The following is a description of a gene set: The aim of this study was to identify genes regulated by IL-12, IL-18 and IFN-alpha during early differentiation of human Th1 cells Genes up-regulated in the activated CD4 T cells (48h): IL-12 and IL18 versus interferon alpha. from publication Filén S, Ylikoski E, Tripathi S, West A, Björkman M, Nyström J, Ahlfors H, Coffey E, Rao KV, Rasool O, Lahesmaa R (PMID 20304822) studied in species Homo sapiens Human Gene Set: GSE20198_IL12_IL18_VS_IFNA_TREATED_ACT_CD4_TCELL_UP, and this is the list of marker genes: TRIM35, NUDT18, PLEKHA5, PHB2, TCOF1, BRCA2, FADS1, PSMD14, MGMT, GUF1, FLI1, CLHC1, IL4I1, PRKCD, IFT56, RNF38, ZFR2, TFB1M, AIM2, MRS2, OSBPL7, SEL1L (NCBI Gene Id 6400), ALDOC, SMIM30, ITPRIPL2, BCL2L2, ZBTB9, STX4, INPP5B, NFIX, CIC, FLYWCH1, SLAMF6, TIMM8B, ZXDC, FBXO45, IPO11, METTL26, PAFAH2, IFT46, GSK3A, SCLY, PREB, CNPY4, MTHFD1L, PAPOLG, STMP1, TIFA, PSPH, MEDAG, DNAJC19, RPL3, NTHL1, ATP6V0A1, MRPL47 (mitochondrial ribosomal protein L47), XPO6, PRR14, PRKCSH, COX16, YWHAH, DYNLT2B, ZDHHC4, STK26, SMAD1, TPRA1, PITHD1, RCBTB1, ARMC2, ECI1, SESN3, AGRP, SMCO4, EIF4ENIF1, FAM161A, RPS8, HMG20A, CARD6, PIP4P2, BAX, BIN1, HELB, ZC4H2, AP1B1 (adaptor related protein complex 1 subunit beta 1), ZSWIM7, TMEM198, SLC39A3, ZMAT2, UNC50, ZNF692, NDRG3, MPEG1, C1orf174, KCTD11, ZC3H12D, PDE6D, TRAM2, ARFIP1, RAMP1, NUDT13, DNLZ, FBXO25, SPICE1, C1orf74, OPA1, IFT74, CCDC6, TBC1D13, RPUSD3, CHAF1B, TACC1, LGALS1, ASB4, FRA10AC1, ARHGAP22, DOCK6, NUDT12, NR1H2, POLR2I, VPS39, CSAD, ZMYND11, GLRX, SPPL2A, FGD5, GUSB, VAMP4, KLF7, PLBD2, TMA7, GANAB, ENDOU, DDX28, DNAJC10, SAA4, SLC52A3 (solute carrier family 52 member 3), PTPRCAP, AAMP, RAP2B, FKTN (NCBI Gene Id 2218), PPIH, CELA1 (chymotrypsin like elastase 1), GABRD, PHTF1, SFXN2, THAP11, UCHL1 (ubiquitin C-terminal hydrolase L1), SLC25A28, SPI1, SCAF1, EXOSC5, SERF2, UPF3A, KCNAB2, TTI1 (NCBI Gene Id 9675), DMAC2L, IDH3B, GATB, KIF3C, OTUD5, PARVG, THY1 (Thy-1 cell surface antigen), POLD2, ZNF606, CPSF1, DUS1L, C9orf85, RASSF2, IP6K1, CTH, GIT2, CCNDBP1, PCK2, GPR89B, NHERF2 (NCBI Gene Id 9351), TRIM68, SLC6A4, UXS1, APOBEC2, CA9, ARSK (arylsulfatase family member K), IKBIP, SATL1, CYP51A1, SKAP1, GMDS, RMND1, HIVEP3, CBFA2T2, KBTBD11, GCFC2, TRIM41, TEX19, SF3B2, TMEM60, SLC25A13, C6orf62, NAA35, SPPL3, RNF123, MMS22L